Given this list of marker genes Adcy7, Gnai1, Adcy5, Gnat3, Adcy8, here is a description of the gene set: This event has been computationally inferred from an event that has been demonstrated in another species.<p>The inference is based on the homology mapping from PANTHER. Briefly, reactions for which all involved PhysicalEntities (in input, output and catalyst) have a mapped orthologue/paralogue (for complexes at least 75% of components must have a mapping) are inferred to the other species. part of: Activation of GABAB receptors; G-protein mediated events electronically inferred by orthology from the curated human pathway studied in species Mus musculus Reactome Pathway: Adenylate cyclase inhibitory pathway